Given this list of marker genes MUC13, ST3GAL3, MUC4, MUC12, MUCL1, MUC20, MUC5AC, MUC5B, ST6GALNAC2, MUC6, MUC3A, MUC17, ST6GALNAC4, MUC7, MUC21, ST6GAL1, MUC15, ST6GALNAC3, ST3GAL4, MUC16 (NCBI Gene Id 94025, mucin 16, cell surface associated), MUC1, ST3GAL2 (NCBI Gene Id 729518), ST3GAL1, here is a description of the gene set: Termination of O-glycan biosynthesis studied in species Homo sapiens Human Gene Set: REACTOME_TERMINATION_OF_O_GLYCAN_BIOSYNTHESIS